The following is a description of a gene set: Mouse Gene Set: REACTOME_AMINE_LIGAND_BINDING_RECEPTORS Amine ligand-binding receptors species: Mus musculus, and this is the list of marker genes: Adra1a, Drd1, Htr2b, Drd2 (dopamine receptor D2), Htr6, Hrh4, Chrm1, Taar9, Adra2c, Htr1a, Hrh3, Htr1d, Adra2b, Taar5, Htr5a, Gpr143, Drd4, Htr4, Htr2a, Taar3, Taar1, Hrh2 (NCBI Gene Id 15466), Drd3, Taar8b, Chrm5, Taar2, Adra1b, Adrb3, Htr1f, Adra2a, Hrh1, Adrb2, Adra1d, Htr1b, Htr7, Chrm3, Taar6, Chrm2, Adrb1, Htr2c, Chrm4, Taar8c, Drd5